The following is a description of a gene set: The part of synaptic transmission occurring in the post-synapse: a signal transduction pathway consisting of neurotransmitter receptor activation and its effects on postsynaptic membrane potential and the ionic composition of the postsynaptic cytosol. Human Gene Set: GOBP_CHEMICAL_SYNAPTIC_TRANSMISSION_POSTSYNAPTIC studied in species Homo sapiens, and this is the list of marker genes: DRD2, HTR3C, NETO1, CHRNA10, SNCA, ADORA1, S1PR2, RGS4, HTR3D, NPY2R, CHRNB1, PRKAR1B (protein kinase cAMP-dependent type I regulatory subunit beta), GRIK2, CHRNG, LRRK2, CHRNA2, ARRB2, ADORA2A, SLC8A3, MIR30B, DMPK, GABRB3, ABAT, CHRNA6 (NCBI Gene Id 8973), TRPV1, GHRL, DRD4, TMEM108 (transmembrane protein 108), CHRNA7, PPP3CA, NRXN1, CHRNA4, RAB3GAP1, EIF4A3, SEZ6, NPFF, ATXN1, GRIN1, BEGAIN, GLRB, P2RX1, NOTCH1, CUX2, GRIN2C, NPAS4, CELF4, PRKCZ (protein kinase C zeta), APP, SLC8A2, P2RX5, MET, NLGN2, CDK5, RIMS1, GRIN2D (NCBI Gene Id 9164), STX1A, SLC17A7, GRIK5, GLRA2, SSH1, MPP2, KCNK2, GSK3B, CHRNA1, ADRB2, SHANK1, BAIAP2, CBLN1, CHRNA5, DVL1, NLGN3, GSK3A, RELN, P2RX3, NLGN1, GLRA3, SLC1A7, CHRNB2, GRID2, MEF2C, GRIA1, TMEM25, PTEN, INSYN1, CHRNA9, HTR3B, INSYN2A, NTSR1, RIMS2, PRKN, MAPK8IP2 (NCBI Gene Id 51748), SHANK3, MTMR2, PTK2B, P2RX4, EEA1, SLC29A1, CHRNB3, HCRT, MECP2, DLG4, P2RX6, CHRNE, CHRNA3, CHRND, ZMYND8, UNC13B, TBC1D24, GRIN2A, GLRA1, WNT7A, HTR3A, CHRFAM7A (NCBI Gene Id 89832), NLGN4X, P2RX7, P2RX2, STX1B, HTR3E, AKT1, GRIN2B, CHRNB4